Given this list of marker genes HTR2B, PDGFB, HTR2A, HTR2C (NCBI Gene Id 3358), PDGFA, here is a description of the gene set: studied in species Homo sapiens Any process that modulates the frequency, rate or extent of the chemical reactions and pathways resulting in the formation of phosphatidylinositol. Human Gene Set: GOBP_REGULATION_OF_PHOSPHATIDYLINOSITOL_BIOSYNTHETIC_PROCESS